Given this list of marker genes PPARG, MAP2K5, MIR543, KANK1 (KN motif and ankyrin repeat domains 1), CSNK2B, PLCB1, ATP2B4, SINHCAF, MIR138-1, WNT3 (Wnt family member 3), MIR29C, MIR551A, SEMA5A, MIR29B1, MIR4500, CYP19A1, MCTP1, EVL, MAGI2, MIR361, PTPRK, ENG, MIR214, SEMG1, MEF2C, SRGAP2C, IFITM1, ABHD6 (abhydrolase domain containing 6, acylglycerol lipase), GREM1, TMIGD3, PODN, CLIC4, MITF, HRG, SPRED1, SAP30L, DPYSL3, RBBP4, STC1, CLDN5, ADA, MIR451A, HOXA7, APOD, CDH11, GHSR, MIR638, SEMG2, MIR137, HDAC1, MIR101-1, MIR588, CHRD, SLIT2 (NCBI Gene Id 9353), CCN3, MIR126, IL27RA, NAV3, MIR9-1, MIR26A1, PTPN1, MIR21 (NCBI Gene Id 406991), NR2F2, GPR173, BMP10, AP1AR, MIR34A, DAB2IP, DLL4, NDRG4, TBXA2R, MIR320A, KLRK1, RIPOR2, ING1, MIR29A, HMGB1, NRG3, MIIP, PTPRR, SLAMF8 (SLAM family member 8), SFRP1, PIN1 (peptidylprolyl cis/trans isomerase, NIMA-interacting 1), HDAC2, SRGAP3, MIR204 (NCBI Gene Id 406987), MIR492, MAPK15, MMRN1, ROBO4, ADGRB1 (NCBI Gene Id 575), MIR146A, STARD13, TNFAIP6, MIR185, ACVR1C, PTPRT, MIR93, PTPRO, MMP28, CYGB, MECP2, MIR640, CYP1B1, TNN, SVBP, PADI2, MIR410, MICOS10-NBL1, JAG1, STAP1, NEDD9, JUP, CLDN19, CLASP1, STK26, CNN2, ING2, NODAL, GTPBP4, MIR2355, SRGAP2, SAP130, WNT4, CERS2, MIR145, GPR18, DUSP3, TET1 (NCBI Gene Id 80312), RIN3, DUSP10, SRGAP2B, PTPRJ, MIA3, DAG1 (dystroglycan 1), THY1, TP53INP1, ERBB4, MMRN2, OSBPL8, MIRLET7A1, WAS, DNAJA4, SP100, SMAD7, EPHA4, MIR665, DLC1, CFL1 (cofilin 1), HMOX1, CLASP2, CITED2, IL24, MEOX2, BMERB1, SRF, ELANE, APOE, PATZ1, MIR193A, GDF15, GNA12, GADD45A, MIR132, BST2, KRT16, AFDN, RAP2A, C5, BMP5, FBLN1, MIR152, MIR494, MIR133A1, ARHGDIB, ADIPOR1, MIR92B, VCL, MIRLET7B, AIF1, NOTCH1, RAP2B, APOH, MIR16-1, ARHGAP4 (Rho GTPase activating protein 4), IL4, ADAMTS9, TGFBR1, MIR338, SERPINE1, TACSTD2 (NCBI Gene Id 4070), RBBP7, RECK, ARID4A, THBS1, SLIT1, DLG5, MARVELD3, MCC, NRP1, AKT1, MIR200C, MIR196A1, MIR129-1, SRGAP1, ITGB1BP1, MIR503, VASH1, WNT3A, CX3CL1, MIRLET7G, PIP5KL1, GNRH1, RYK, MYOCD, GCSAM, RHOB, SFRP2, TBX5, KRIT1, MIR19A, NF2, DSG3, WNT5A, GSK3B, TRIB1 (NCBI Gene Id 80272), ALOX15B, NF1, SIN3B, DNAI3, IL33, ZEB2, MIR22, PDCD10, SLURP1, SPOCK3, CALR, TNF, DACH1, RABGEF1, PFN2, CCL25, ANGPT2, DPEP1, ARID4B, ZMYND8, OGT, PLXNA3, MIR10A, CTNNA1, RHOA, TMEFF2, MIR199A1, MIR493, CRK (NCBI Gene Id 1398), EPPK1, MIR212, MIR24-1, GATA3, BCR, TMEM196, RNF20, MIR885, BMP4, NFE2L2, MIR223, MIR221, MIR379, TPM1, MIR182, LRP1, FUZ, DPP4, SERPINB1, NEXMIF, RGCC, DRD2, MIR200B, GJA1, CXCL12, IGFBP5, PTPRM, ADORA3, FIGNL2, LDLRAD4, CXCL13, MIR335, PLXNB3, MIR133B, AGTR2, DUSP1, ADIPOQ, CD200, NISCH, MIR3173, COL3A1, MIR362, IGFBP3, LRCH1, CCL21, CCL2, EPPIN, CARD10, TCAF1, FGF2, BMPR1A, MIR128-1, ARID2, SULF1 (sulfatase 1), MIR892B, CCL28, MACIR (macrophage immunometabolism regulator), NHERF1, ACVRL1, CCDC125, MIR495, BRAF, IDH2, MIR218-1, MIR19B1, HDAC6, FOXO3, HAS1, PHLDB2, SERPINF1, HDAC5, MIR92A1 (NCBI Gene Id 407048), MIR497, ARRDC3, SIN3A, CD69, DDT (NCBI Gene Id 91323), CORO1B, PTPN23, MIR206, RAC1, RNF41, PRKG1, TIMP1, NKX2-1, CORO1C (coronin 1C), KLF4, TGFB1, ATP1B2, CD74, ROBO2, CLDN3, CD200R1, EPHA1, MIR520D, PTPRU, DUSP22, SYNJ2BP, NBL1, TGFBR3, PTEN, PTGER4, MIR1298, MIR483, WASL, HYAL2, MIR424, NGFR, CD63, MIR15A, DCN (decorin), GHRL, MIR30C2, LIMCH1, MIR20A, MIR329-1, BCL2, NOG, MIR224, KLRC4-KLRK1, EMILIN2, CD300A, MIR1-1, SHH (NCBI Gene Id 6469), ADORA1, SEMA6D, ANGPT4, SPINT2, SCAI, ADTRP, MIR449A, BRMS1L, ADGRG1, GDF2, PTPN2, ABCC8 (NCBI Gene Id 6833), MIR205, PTPRG, TIE1, MIR140, SUDS3, ROBO1, MIR15B, PPARD, MIR130A, STK24, STAT3, MIF, ADARB1, ABHD2, BRMS1, ARPIN, SEMA3F, RRAS, MIR491, EMILIN1, MIR149, MIR31, MIR505, C5AR2, FRMD5, CDH1, GSTP1, ADAM15, SAP30, RAP2C, here is a description of the gene set: Any process that stops, prevents, or reduces the frequency, rate or extent of locomotion of a cell or organism. studied in species Homo sapiens Human Gene Set: GOBP_NEGATIVE_REGULATION_OF_LOCOMOTION